Given this list of marker genes GDAP1, JAG1, LONP1, GIPC1, PRX, HAAO, SH3TC2, NOTCH2NLC, MATR3, TRPV4, MFN2, LRP12, DST, SLC5A7, RILPL1, here is a description of the gene set: Human Gene Set: HP_VOCAL_CORD_PARESIS Decreased strength of the vocal folds. Vocal cord paresis species: Homo sapiens